The following is a description of a gene set: species: Mus musculus Mouse Gene Set: GOBP_REGULATION_OF_CARDIAC_MUSCLE_ADAPTATION Any process that modulates the rate, extent or frequency of the process in which cardiac muscle adapts, with consequent modifications to structural and/or functional phenotypes, in response to a stimulus. Stimuli include contractile activity, loading conditions, substrate supply, and environmental factors., and this is the list of marker genes: Acacb, Errfi1 (NCBI Gene Id 74155), Mlip (NCBI Gene Id 69642), Atp2b4, Ppp3ca, Smad3, Trpc3, Pparg, Bmp10, Oga (NCBI Gene Id 76055), Foxo1, Lmna